The following is a description of a gene set: species: Homo sapiens Parietal foramina The presence of symmetrical and circular openings (foramina) in the parietal bone ranging in size from a few millimeters to several centimeters wide. Human Gene Set: HP_PARIETAL_FORAMINA, and this is the list of marker genes: ZIC1, MSX2, FGFR3, PHF21A, EXT2, EP300, CREBBP, FGFR2, RPS19, TWIST1, PPM1D (NCBI Gene Id 8493), ZSWIM6, RNU12, ALX4